The following is a description of a gene set: Genes down-regulated in comparison of dendritic cells (DC) stimulated with Pam3Csk4 (TLR1/2 agonist) at 0.5 h versus those stimulated at 12 h. from publication Amit I, Garber M, Chevrier N, Leite AP, Donner Y, Eisenhaure T, Guttman M, Grenier JK, Li W, Zuk O, Schubert LA, Birditt B, Shay T, Goren A, Zhang X, Smith Z, Deering R, McDonald RC, Cabili M, Bernstein BE, Rinn JL, Meissner A, Root DE, Hacohen N, Regev A (PMID 19729616) mouse primary BMDCs were stimulated with tlr ligands and gene expression changes were profiled on Affymetrix arrays species: Homo sapiens Human Gene Set: GSE17721_0.5H_VS_12H_PAM3CSK4_BMDC_DN, and this is the list of marker genes: CSDE1, SLC46A2, CDKN2AIPNL, MS4A7, TLR8, GK, TRAPPC13, METTL6, VAPA, PNO1, VPS26A, IGF2BP1, CNOT8, PARP12, DNAJB6, BCKDHB, NCF1, MFSD1, PRPH, TLK2, ACSS2, CD9, ETFBKMT, ITGB1BP1, SLC8B1, RNFT1, ATE1, CDC25A, ARHGAP5, UBE2G1, ESD, POLR2G, PSMD10, GLIPR1, RAC2, TPRKB, VDAC3, JDP2, KATNBL1, CLCN7, BMP6, TSPAN3, SNTB2, ASH2L, ELK3, C18orf32 (chromosome 18 open reading frame 32), GSS, SIKE1, COPB1, SPART, RBM7, ZNF841, WNK4, TTC17, MYO1B, RHOT1, VCAM1, GPR85, PITPNM1, MTF2, NFKB1, POU2F2, ZC3H11A, TMEM134, TMA16, PSMA4, PAPSS1, NUB1, EIF3E, USP10, KIF1B, PSMA1, PHF3, PFKP, NUS1, DKKL1, IPO5, RRAS, SPATS2, GDI1, CHMP5, MDM2, RASGRP1, COASY, SIRT4, ZBTB7B, ACTR8, SMIM3, SEPTIN7, MECR, CAPZA1 (NCBI Gene Id 829), C11orf58, RSAD2, LRRC59, EMC4, CAT, PPP2CB, S1PR1, NET1, GFM2, AUP1, ZDHHC12, IL36A, RAB22A (RAB22A, member RAS oncogene family), NDE1, CDK2AP1, FLCN, MYL10, ANAPC7, AASS (aminoadipate-semialdehyde synthase), MIS12 (NCBI Gene Id 79003), TRIP4, BST1, ARL8A, TNFAIP2, PSMD12, UBE2W, LPP, TMCO3, UBE2C, KPNA1, ACSL1, WRAP53, PGLYRP2 (peptidoglycan recognition protein 2), CDC27, COQ3, OST4, PAM16, CDV3, ATF4, XYLT2, CD200, MCFD2, VTA1, CLIP1, EMG1, DYNLT3, VTI1A, STUB1, ADAD1, CGGBP1, TRMT2A, TRIM59, SHPRH, PDIA5, ARFGEF1, ERGIC2, ACYP2, RNF121, BECN1 (NCBI Gene Id 8678), FPR1, SPIDR, KHDC4, VPS35, DUSP19, IMP3, AMFR, PRDM9, CLK4, CMTR1, NPAS3, AZIN1, HAX1, ZNF451, BCDIN3D, YAE1, ASF1A, UBXN2A, KICS2, CACFD1, SGMS1, CCR8, GFER, PHF10, AEBP2, PPT2, GRAMD1A, KCTD14, SEMA4A, IL36G, PLA2G2E, PHF21A, AP1S1, ATP6V0B, ZC3H14, SPPL2A, ACSL5, COPG1, ARHGEF3, ATOSB, HEPH, NOL11, TARS1, ECI2, USB1, SRP54, ITGAV, IMPA1, MAN1A2, PPP2R3C